The following is a description of a gene set: Human Gene Set: HP_ILEUS studied in species Homo sapiens Ileus Acute obstruction of the intestines preventing passage of the contents of the intestines., and this is the list of marker genes: MTRFR, CFTR, CEACAM6, SLC6A8, DCTN4, GSTM3, HMOX1, CLCA4, HMBS, FCGR2A, KIF26A, EWSR1, SLC18A3, SLC26A9, WT1 (NCBI Gene Id 7490), FOXP3, ARPC5, SLC6A14, SERPINA1, FAH, HFE, CAVIN1, CEACAM3, SLC9A3, MIF, STX1A, GUCY2C, SLC11A1, TGFB1, GCLC, KCNN4, EDNRA, SOX10, PPOX